The following is a description of a gene set: This event has been computationally inferred from an event that has been demonstrated in another species.<p>The inference is based on the homology mapping from PANTHER. Briefly, reactions for which all involved PhysicalEntities (in input, output and catalyst) have a mapped orthologue/paralogue (for complexes at least 75% of components must have a mapping) are inferred to the other species. electronically inferred by orthology from the curated human pathway part of: Hemostasis Reactome Pathway: Platelet activation, signaling and aggregation studied in species Mus musculus, and this is the list of marker genes: Itih4, Lhfpl2, Gp1ba, Rac2, Adra2c, Gng5, Trpc7, Pik3cb, Tex264, Alb, Psap, Nhlrc2, Grb2, Hrg, Gna14, Stxbp3, Gngt1, Spp2, Orm2, Dgkb, Orm1, Aplp2, Maged2, Gnat3, Gtpbp2 (GTP binding protein 2), Lamp2, Adra2a, Gng3, Prkch, F8, Gas6, Rab27b, Pcdh7, Srgn, Dgki, Mapk3 (NCBI Gene Id 26417), Mmrn1, Gng11, Ptpn1, Apoa1, Mpig6b, Dagla, Gng4, Ptpn6, Crk, Gng8, Serpinf2, Islr, P2ry1, Gng7, Sparc (NCBI Gene Id 20692), A2m, Gnb2, Apbb1ip, Arrb2, Gnai1, Shc1, Ahsg, Aldoa, Trf, Tgfb1, Serping1, Gnb3, Itih3, Csk (NCBI Gene Id 12988), Rasgrp1, Ly6g6f, Fam3c, Timp1, Prkca, Vegfd, Tuba4a, Pcyox1l, Cdc42, Mapk14, Itga2b, Pdpn, Tmx3, Pik3r5, Col1a2, Fyn, Pdgfa, Cdc37l1, Cfd, Cd109, Dgka (diacylglycerol kinase, alpha), Gng10, Fgg, Vegfa, Lgals3bp, Calm1, Brpf3, Syk, Pdgfb, F13a1, Pros1, Vegfc, Apoh (apolipoprotein H), Tbxa2r, Dgkh, Vav1, Selp, Tor4a, F2rl3, Bcar1, Cd9, Gna12, Hgf, Lck, F2, Rhob, Daglb, Pik3r2, Chid1, Gp1bb (glycoprotein Ib, beta polypeptide), Gna13, Rarres2, Plcg2, Adra2b, Tmsb4x, Abcc4, Igf2, Pdpk1, Kng2, Trpc6, Lat, Ptk2, Scg3, Vegfb, Cd36, Gp9, Stx4a, Pf4, Gnb5, Plg, Gngt2, Sytl4, Ctsw, Prkcg, Tln1, Lcp2